Given this list of marker genes APOB, CIDEB, APOC1, FECH, ACSL3, SOAT2, DGAT1, MFSD2A (MFSD2 lysolipid transporter A, lysophospholipid), MTTP, LPCAT3, SOAT1, APOC3, here is a description of the gene set: studied in species Homo sapiens Human Gene Set: GOBP_VERY_LOW_DENSITY_LIPOPROTEIN_PARTICLE_ASSEMBLY The non-covalent aggregation and arrangement of proteins and lipids in the liver to form a very-low-density lipoprotein particle.